Given this list of marker genes SAA1, CD2AP, RB1, TWNK, NUP133, CIITA, CAV3, PKD1, LPIN2, RFC2 (NCBI Gene Id 5982), UBAC2, ENO3, TRPS1, ERCC3, ZFX, TGFB2, TREM2, WIPF1, CTNS, RIPK1, EWSR1, CCN6, MYLK, OPA1, PON3, PTPN22, IL2RB, ALG9 (ALG9 alpha-1,2-mannosyltransferase), COL2A1, COL5A2, CFAP410, DNASE1L3, ACTN4, EPAS1, IKZF1, TP53, HPDL, F8, LPIN1 (NCBI Gene Id 23175), TSC1, MT-TE, ERCC4 (ERCC excision repair 4, endonuclease catalytic subunit), ARHGAP24, AGXT, GNE (glucosamine (UDP-N-acetyl)-2-epimerase/N-acetylmannosamine kinase), FGF13, RYR1, LMO1, MMP2, MYL4, DLEC1, COL3A1, GATA4, TRPV6, WNT1, UBQLN2, SPTLC1, DKK1, PGAM2, SLC25A4, SLC34A1, SCN5A, PHEX, PLAG1, ALDOB, AP1S3, KCNE1 (potassium voltage-gated channel subfamily E regulatory subunit 1), EMD, ERBB3, P4HA2, IRF2BP2, BCOR, CAV1, SPP1, ZNRF3, NCF1, GNB2, ZMYM3, FAS, NTRK1, EDNRB, PML, PCSK9, TGFB1, PFKM, COQ7, MITF, KCNQ1, PTPN6, TLR7, LEMD3, SRP19, ANG, ATP7A, DUX4L1, MUTYH, POLE, CDKN2B, PSAP, DBH, VCP, MFN2, C1R, ZFTA, FOXE3, SLC25A11 (NCBI Gene Id 8402), CALR, HLA-DPB1, PIK3CG, BAP1, GUCY2C, MT-TK, NNT, VAPB, C4A, ANK1, ERCC2, ENG, NUMA1, EXT2, PGK1, TONSL, SMO, IDH1, KIF1B, AAGAB, ADAMTS19, LRP12, GTF2IRD2, NPRL3, GLA, EMP2, ABCC6, STAT6, PHKG2, MED12, GATA5, SEMA3D, SCO2, GNA11, CLCN1, SCN9A, CAVIN1, CRLF1, CTNNB1, PDGFRA, LMNB1, ACAD9, CDKN2A, REEP2, KCNE3, PKD2, RNF168, POLR3A, MST1, FKBP6, CPA1, TBL2, NKX3-2, SLC22A4, POLG2, TRIM32, SCNN1G, MT-ATP6, PHKA2, PLCG2, RAD51, SMAD4, TMEM43, STING1, ANKH, MATN3, MYC, CCN2, SCN4A, ARHGDIA, CHCHD10 (NCBI Gene Id 400916), DMPK, DNAJB6, ELANE, GDF3 (growth differentiation factor 3), SLC26A2, ARSB, COL11A2, GDF6, SDHB, TSC2, TRIM28, GNPTAB, CD247, THSD4, CHST6, MAP2K1, APRT, CRB2 (crumbs cell polarity complex component 2), CDKN2C, AMPD3, PALLD, MMP13, NOD2, GLE1, TNFRSF11A, TYMP, COX6B1, PSMB8, RASA1, CCDC78, NPPA (natriuretic peptide A), TRIP13, NCF4, GNAS, SERPINF2, ATRX, KCNJ2, MC2R, CPOX, GLT8D1, ELN (NCBI Gene Id 2006), TK2, CPT2, CR2 (NCBI Gene Id 1380), TRAF7, PIGT, SEMA3C, PLCE1, ATP8B1, CDKN1C, PFN1, COMP, SAT1, FH, VHL, NFKBIL1 (NFKB inhibitor like 1), FERMT3 (NCBI Gene Id 83706), APOL1, IRF5, SCN4B, HTRA1, AMPD1, TPM2, ADA2, ACADM, G6PD (NCBI Gene Id 83159), DNMT3B, AKT1, TRAPPC11, SCNN1A, MMUT, CCR6, SPTB, CHMP2B, FBN1, BIRC3, NUP205, BMP2, ABCD1, PRSS1, PRKAG2, SCN11A, SYK, ASPN, PMS1, MNX1, TNNC1, POU6F2, HARS1, PRKRA, ZBTB16, KRAS, HNRNPA2B1, SPG7, ECE1, PRPH, SCN3B, CYSLTR2, ABCC9 (NCBI Gene Id 102724274), TNFRSF11B, COQ8B, EPOR, SDHAF2, CLCN5, NF1, TEK, PNPLA2, MTMR14, ANKFY1, OPTN, CLCNKB, DNAL4, RABL3, IDUA, TACSTD2, TGFB3, POLR3GL, TMEM126B, SCN10A, SEMA4A, AIP, SCN2B, TERT, PHKA1, STOX1, RRM2B, IL6, SERPING1, EPB41, COL11A1, CDKN1A, PIEZO1, NRTN, PPARGC1A, TRPM4, PPARG, PLEKHM1, ANTXR1, PRDM5, TBX18, GPR101, FHL1, SLC22A12, SPTA1, FMR1, NGLY1 (N-glycanase 1), PTPN3, HPS1, SEC24C, DNM2, ABCB4, DDB2, MLH1, CCR1, UFSP2, ERBB2, THPO, ANO5, RNU4ATAC, MEF2A, WWOX, MAT2A, RAD21, ATXN3, POMT1, GRHL2, HSPG2, B2M, ABCB11 (ATP binding cassette subfamily B member 11), KLRC4, ATP7B, EIF4H, TET2, PIGA, TCF4, PIK3CA (NCBI Gene Id 5290), IL12B, TCIRG1, NGF, PHKB, METTL27, MRAP, NUP85, RREB1, SLCO2A1, CACNA1S, MMP1, FLT1, TTN (titin), HMGCR, MME, TARDBP, KCNJ5, EDN3, DGUOK, NFKB2, C1S, SPTBN1, COPA, MCM6, COL4A3, ATL3, GPC3, MALT1, HMBS, STX16, AEBP1, TREX1 (three prime repair exonuclease 1), HLA-DPA1, SQSTM1, IGHG2, CARS2, HLA-B, CYP2R1, GTF2IRD1, ATP2A1, CRPPA, GHSR, MAGI2, TRPV4, PRKAR1A, MESP2, LZTR1, GANAB, PSTPIP1, XPC, CARD8, MSTO1, WRN, ZMPSTE24, GDNF, PNPT1, CASK, TNFSF12, TNFSF11, ATM, DSG2, FN1, LOX, OPLAH, CYP27B1, XPA, PTEN, SFRP4, SH3TC2, IL36RN, SDHD, DNM1L, ZNF687, SLC34A3, MLIP, SNX10, CYB5A, MINPP1, OTC, CEBPE, GATM, ARVCF, F12, ALDH18A1, NEFH, IL12A, DCTN1, NUP160, MATR3, CLCN7, DSE, TBL1XR1, IL1R1, GJA5, MIF (NCBI Gene Id 4282), SLC25A42, DAO, NLRP12, IFNGR1, SOX10, DPM3, WAS, PORCN, PTPN2 (NCBI Gene Id 5771), ANXA11, POLD1, ACP5, CAPN3, MDH2, CTLA4, NDUFAF6, ATXN2, ALG5, COL4A5, STAR, SMARCB1, COL17A1, SLC26A1, PALB2, PTH1R, PMP22, MFAP5, IL23R, CEL, TGFBI (transforming growth factor beta induced), OTULIN, NUP155, KRT6B, DNAJB11, MSH2, PYGM, GNA14, FRG1, ERBB4, STAT4, TRPC6, ACTC1, MYO1E, DLST, SPTLC2, MRPS2, IL1RN, EPB42, RET, INF2, CCNF, TNFRSF13C, ZNF469, RPS20, SCARB2, FTL, NOS1, LPL, BRCA2, TGFBR2, COL8A2, ACADVL, NKX2-5, ERAP1, RARA, HBB (hemoglobin subunit beta), SLC4A1, HYAL1, PHKG1, SLC2A9, TYROBP, NLRC4, GJB6, MS4A1 (NCBI Gene Id 931), SMARCE1, IFT140, RUNX1, SDHA, MSH6, BRCA1, CLIP2, SREBF1, PMS2, HLA-DRB1, EHHADH, AP2S1, CLPB, NKX2-6, SEPTIN9, CHST3, FOXE1, IL12A-AS1, BCL11A, SLC34A2, TMEM127, MPL, COL9A1, NOTCH2, MSMO1, HADHB, HBG2, APC, DNMT3A, ALDH4A1, KRT14, OPA3, MYH11, MAFB, COL4A6, PHOX2B, COL9A3, DYSF, FIG4, KRT5 (NCBI Gene Id 3852), JAK2, CFTR (CF transmembrane conductance regulator), PRTN3, TNFRSF13B, LIG3, NAB2, CD244, CDC73, HABP2, LBR, CYP19A1, CASR, HMGA2, FLNC, NPHS2, DLL3, KRT17, C1QB, ATL1, CHEK2, FDX2, TBC1D8B, LMNA, HPGD, ERCC5, IRAK1, SDHC, PAX2, AGBL1, UNC13A, VANGL1, PKHD1 (NCBI Gene Id 5314), MET, GTF2I, SLC25A26, CYP17A1, MT-CO1, SPAST, PSMB4, COL10A1, APOB, DCC, ALDOA, IDH2 (NCBI Gene Id 3418), GP1BB, TBK1, NF2, FIP1L1, FKTN, LACC1, CLDN16, SYNE1, BMPR1A, FKRP, IGKC, HS3ST6, NUP93, PRKG1, F5, ASAH1, UQCRH, STK11, GBA1, IGF2, BAZ1B, CDKN1B, DGAT1, LRP5, PRNP, LMNB2, ELF4, TBX6, LDLR, IL2RA, SCN1B, NRAS, ACTA2, FLI1, MDM4, CD55 (NCBI Gene Id 1604), LDLRAP1, SMAD3, TMEM270, KRT6A, PON2, HEY2, PIGY, BTNL2, FSHR, CORIN, DUX4, SYNE2, LYN, HOGA1, STX1A, MYOT, TGFBR1, SLC40A1, MYCN, SVIL, NLRP3, ESR1, FUS, BVES, ACVR1, STAT5B, ASXL1, KCNA5, MEN1, ICOS, HIRA, ZEB1, CD19 (NCBI Gene Id 930), GNPTG, ABCG5, GPR35, SUFU, SOD1, LDHA, DMD, MLYCD, POLG, HLA-DQB1, MYF6, KIF7, HACE1, JMJD1C, COL6A1, LIMK1, CNBP, KLF1, BMP4, PTPN11, NFKB1, BRAF (NCBI Gene Id 673), OVOL2, SLC39A14, EXT1, CD46, BIN1, HELLPAR, SMCHD1, HFE (homeostatic iron regulator), LMX1B, GAPVD1, SEMA4D, NABP1, FGF23, ANTXR2, BICC1, TREH, KCNJ3 (potassium inwardly rectifying channel subfamily J member 3), SEC63 (SEC63 homolog, protein translocation regulator), VPS37D, SCNN1B, HEXB (hexosaminidase subunit beta), ERLIN1, ROS1, BUD23, FILIP1, PPA2, STIM1, ABCG8, PITX2, SMPD1, CCND1, GNAQ, GK, NTN1, ALAD, HGD, COMT, SI, NPM1, SPINK1, FOXP1, ACTG2, NPRL2, WASHC5, GYPC, GCGR, VDR, IRF4, HNRNPA1, CD81, LRP1, NUP37, MPV17, MYBPC3, HEPHL1, GATA6, SRSF2, CAT, LIN28B, ALMS1 (ALMS1 centrosome and basal body associated protein), UFD1, HADHA, ORAI1, CFI, PLAAT3, BCL10, KY, KIT, PRSS2, TLR4, WT1, SMAD2, MT-CO3, PLN, TRAPPC2, TNFRSF1A, MVK, SF3B1, VSX1, PKDCC, IL10, MAX, SLC12A3, ENPP1, PPOX, POMP, KCNN4, OBSCN, DEPDC5, CTRC, PABPN1, NUP107, SLC4A11, MEOX1, PRORP, BSCL2, RNASEH1, DAAM2, RBCK1, MIEF2, TRPA1, DMP1, SH2B3, WNT3A, COQ6, TNXB, COL14A1, VWA1, MOCOS, MLX, ALK, PON1, ABCA1, DIS3L2, NPHS1, MEFV, GJB2, MYH7, NEK1, MYH3 (NCBI Gene Id 4621), DNAJC30, BMP6, DNA2, ANKRD55, TXNRD2, HBG1, GOSR2, CTSK, FLVCR1, DDRGK1, CDH2, CASQ1, RNF6, REST, COL9A2, PTPRO, UNC45A, PRKCSH, STAT3, KRT16, NR1H4, ANLN, CHST11, COL5A1, KCNE2, SOST, COL7A1, ABCC2, TAF15, COL1A1 (NCBI Gene Id 4970), H19, HLA-DQA1, DDIT3, RNU4-2, TBX1, MTTP, CBL, NAGLU, CFH, EPCAM, MYL2, GFI1, UBA1, PDGFB, here is a description of the gene set: An unpleasant sensory and emotional experience associated with actual or potential tissue damage, or described in terms of such damage. studied in species Homo sapiens Human Gene Set: HP_PAIN Pain